Given this list of marker genes CKAP2L, TMEM174 (NCBI Gene Id 134288), TIMM8B, NUMB, M1AP, MRPL57, ILDR2, ZBTB8A, C11orf54 (NCBI Gene Id 28970), COX19, PRKG2, PHAX, SPATA17 (NCBI Gene Id 128153), GPR158, COLEC12, SPTLC2, PRR11, IKZF3, HAPLN1, APLP1, CDK20, CLIP3, OLA1, IPO9, RINL, MACF1, B4GALNT1, STAU1, SFTPB, CCAR1 (cell division cycle and apoptosis regulator 1), FAM20A, RBL1, RABL3, PNMA2, TM7SF3 (transmembrane 7 superfamily member 3), ASTN1, ZNF552, USP49, GCNT2, CACYBP, H2AZ2, ITGA2, TNFSF10, GJC1, TTPAL, ROR1, POLR2E (NCBI Gene Id 5434), CYP20A1, GGA2, C15orf40, FGB, C16orf82, PNPT1, QPCTL (NCBI Gene Id 54814), NRIP1, IQUB, NCKAP5, FBXO9, GTF2H2, CRISP3, PRDM5, NT5C2, CBX2, ACTR8, RAB3B, AP4S1, NAV1, ADCY2, WFDC8, KCNH4, ETNK1, INPP5F, ST8SIA3, PAQR9, APRG1, ZBP1, ABHD18, HAUS2, ENSG00000255537, ESR2, ATF7IP2, HIVEP3, ADTRP, MAP3K21, ENDOU, CAMK1D, BSDC1, ZNF814, TPD52L1, IPO13, TSR1, SPRYD7, BHMT2, SGO2 (NCBI Gene Id 151246), RAET1E, LPL (NCBI Gene Id 4023), ADGRG4, PAXBP1, FANCM, CBLN2, NLK, ASB7, VCP, PHACTR4, ENPP6, NOM1, IVD, TMEM178B, CSMD3, AAK1, C19orf84, here is a description of the gene set: species: Homo sapiens Human Gene Set: MIR5089_5P from publication Chen Y, Wang X (PMID 31504780) Genes predicted to be targets of miRBase v22 microRNA hsa-miR-5089-5p in miRDB v6.0 with MirTarget v4 prediction scores > 80 (high confidence targets).